The following is a description of a gene set: species: Homo sapiens Human Gene Set: GOBP_REGULATION_OF_LEUKOCYTE_ADHESION_TO_ARTERIAL_ENDOTHELIAL_CELL Any process that modulates the frequency, rate or extent of leukocyte adhesion to arterial endothelial cell., and this is the list of marker genes: ZDHHC21, MIR92A1, ALOX5, TNF, KLF4